The following is a description of a gene set: Pro-apoptotic transcriptional targets of TP53 are TRAIL death receptors TNFRSF10A (DR4), TNFRSF10B (DR5), TNFRSF10C (DcR1) and TNFRSF10D (DcR2), as well as the FASL/CD95L death receptor FAS (CD95). TRAIL receptors and FAS induce pro-apoptotic signaling in response to external stimuli via extrinsic apoptosis pathway. IGFBP3 is a transcriptional target of TP53 that may serve as a ligand for a novel death receptor TMEM219. Reactome Pathway: TP53 Regulates Transcription of Death Receptors and Ligands species: Homo sapiens part of: TP53 Regulates Transcription of Cell Death Genes, and this is the list of marker genes: PPP1R13B, TNFRSF10B, TP53BP2, TMEM219, TP53 (NCBI Gene Id 7157), TP63, TP73, TNFRSF10D, FAS, TNFRSF10A, IGFBP3, TNFRSF10C